The following is a description of a gene set: species: Homo sapiens Human Gene Set: GOBP_REGULATION_OF_PODOSOME_ASSEMBLY Any process that modulates the frequency, rate or extent of podosome assembly., and this is the list of marker genes: FSCN1, TNF, LCP1, SRC, GSN, CAPG, ARHGEF5, RHOA, IL5 (interleukin 5), MSN, HCK, KIF9, CSF2, MAPK9